The following is a description of a gene set: Human Gene Set: GOMF_MUTLALPHA_COMPLEX_BINDING Binding to a MutLalpha mismatch repair complex. species: Homo sapiens, and this is the list of marker genes: MUTYH, MSH6, MSH2, TREX1, ATR, PCNA, WRN